The following is a description of a gene set: Genes predicted to be targets of miRBase v22 microRNA mmu_miR_5625_5p in miRDB v6.0 with MirTarget v4 prediction scores > 80 (high confidence targets). from publication Chen Y, Wang X (PMID 31504780) species: Mus musculus Mouse Gene Set: MIR_5625_5P, and this is the list of marker genes: Hs3st3a1, Onecut2, Zfp764, Sobp, Kctd5 (NCBI Gene Id 69259), Ascl2, Ppfia4 (NCBI Gene Id 98466), Eef2kmt, Zfp462, Sox4